The following is a description of a gene set: studied in species Mus musculus Mouse Gene Set: GOBP_PURINE_NUCLEOSIDE_METABOLIC_PROCESS The chemical reactions and pathways involving one of a family of organic molecules consisting of a purine base covalently bonded to a sugar ribose (a ribonucleoside) or deoxyribose (a deoxyribonucleoside)., and this is the list of marker genes: Pnp, Nt5c1b, Enpp4, Ptgdr, Gnmt, Urad, Bloc1s6, Macrod2, Pnp2, Mtap, Nt5c2, Icmt, Nt5c3, Pcmt1, Uox, Dguok, Ak1, Oard1, Aprt, Pemt, Xdh, Adal, Hprt1, Pgm2, Acp3, Nt5e, Ada, Ahcyl, Adk, Nudt1, Urah, Nt5c1a, Gda, Macrod1, Ahcy, Gamt